Given this list of marker genes PLCG1, NGF, NTRK1, here is a description of the gene set: species: Homo sapiens The activation of phosphlipase C-gamma (PLC-gamma) and subsequent mobilization of calcium from intracellular stores are essential for neurotrophin secretion. PLC-gamma is activated through the phosphorylation by TrkA receptor kinase and this form hydrolyses PIP2 to generate inositol tris-phosphate (IP3) and diacylglycerol (DAG). IP3 promotes the release of Ca2+ from internal stores and this results in activation of enzymes such as protein kinase C and Ca2+ calmodulin-regulated protein kinases. part of: Signaling by NTRK1 (TRKA) Reactome Pathway: PLC-gamma1 signalling